Given this list of marker genes Acaa1a, Acoxl, Acaa1b, Acox2, Acox1, Cpox, Rsad1, Ppox, Acox3, Crat, here is a description of the gene set: Catalysis of an oxidation-reduction (redox) reaction in which a CH-CH group acts as a hydrogen or electron donor and reduces oxygen. studied in species Mus musculus Mouse Gene Set: GOMF_OXIDOREDUCTASE_ACTIVITY_ACTING_ON_THE_CH_CH_GROUP_OF_DONORS_OXYGEN_AS_ACCEPTOR